Given this list of marker genes N4bp3, Alcam, Shank1, Marcks, Ptch1, Mmp3, Nos1, Abl1, Kcnip2, Grin2b, Rangap1, Grik1 (NCBI Gene Id 28183), Ica1, Plcb4, Mylk2, Mdga1, Mapk8ip3, Rph3a, Kcna2, Rgs10, Oprk1 (opioid receptor, kappa 1), Becn1, Gchfr, Slc4a8, Kif5a, Src, Sh3gl2, Dnajb1, Arhgap44 (NCBI Gene Id 216831), Slc1a1, Shisa8, Kcnb2, Cdk5r1, Ephb2, Rgs8, Zdhhc5, Cyp46a1, Osbp2, Shisa7 (shisa family member 7), Drd5, Syt11, Bdnf, Samd4, Htr5b, Hrh3, Kcne3, Prss12, Chrna5, Gabre, Rbm3, Anxa3, Arfgef2, Pabpc1, Dennd1a, Drp2, Rps6-ps4, Tenm2, Ntsr1, Scn8a, Acad9, Ago2, Mme, Itpr3, Gripap1, Kcnk2, Scgn, Calb2, Trpv1, Glra1, Itpr1, Sort1, Maob, Slc18a2, Slc12a5, Wfs1, Mink1, Strn4, Fxr1, Arhgap33, Aatk, Grik4, Dlgap2, Pi4k2a, Maf1, Homer1, Ncf1, Map1a, Lrfn3, Ift20, Robo1, Ppt1, Atp6ap2, Gnai2, Kif1c, Cyp19a1 (cytochrome P450, family 19, subfamily a, polypeptide 1), Kcnk9, Rack1, Septin4, Cd2ap, Cpeb3, Gria3, Srsf10, Mpdz, Penk, Cyp11b2, Rab17, Htr1b, Ppargc1a, Itpka (NCBI Gene Id 228550), Inpp5a, Pias3, Il6st (interleukin 6 signal transducer), C9orf72, Klhl20, Syn1, Grk4, Hspb1, Ucn, Kif21a, Ltbp1, Atp7a, Tanc2, Met (NCBI Gene Id 194383), Hnrnpu, Kif3b, Abr, Hip1r, Dlg3 (discs large MAGUK scaffold protein 3), Rab3ip, Als2, Npff, Hcn1, Zfp804a, Abi2, Hpca, Prex1, Tsc22d4, Ptpn6, Trim3, Adcy8, Fzd4, Slc32a1, Txnrd2, Chrm2, Fubp3, Gabra4, Ephb1, Cftr, Rps6, Ppfia2, Kpna1, Palmd (NCBI Gene Id 66688), Hspa8, Drd4, Cnnm4, Uhmk1, Apba3, Inpp5j (inositol polyphosphate 5-phosphatase J), Abl2, Shh, Hrh4, Gng3, Shisa6, Mtmr2, Kcnc4, Hsp90aa1, Hap1, Il1rapl1, Fzd3, Slc5a7, Itgb1, Lhfpl4, Gria2, Npcd, Glrb, Dab2ip, Slit2, Abi3bp, Rbm8a, Aplp2, Gnas, Strn3, Rufy3, Spg11, Rab8a, mt-Nd1, Syncrip, Atf4, Klhl17, Txn1, Fat3, Adcy9, Adcy4, Farp1, Dcx, Mt3, Zwint, Abhd12, Cabp1 (NCBI Gene Id 29867), Rpl28, Gopc, Homer3, Magi2, Ifngr1, Gabra5, Gnb3, Rin3, Cpe, Slitrk2 (SLIT and NTRK-like family, member 2), Mpp2, Chrna3, Vstm5, Dock10, Ppfia1, Mark1, Htr7, Sv2a, Cript, Thy1, Rtn4rl2, Brinp2, Brinp1, Ddn (NCBI Gene Id 328602), Slc9a6, Fyn, Syngap1, Reg1, Sez6, Chl1, Trappc4, Baiap2, Htr1d, Htr1a, Agap2, Bnip3, Tacr3, Actn1, Gata3un, Nlgn3, Ube2i, Ppp2r1a, Lrit3, Gphn, Epha3, Gpm6a (NCBI Gene Id 234267), Lgi1, Asic2, Wdr47, Pnmt (phenylethanolamine-N-methyltransferase), Ntf5, Kndc1, Lamp1 (NCBI Gene Id 234071), Cacng8, Cobl, Lama2, Ppp1cc, 4930544G11Rik (NCBI Gene Id 67653), Nf1, Gnb5, Ptprk, Epm2a, Grm3, Drd2, Numa1, Snx14, Pum2, Pcsk2, Pdyn, Whrn, Eif4b, Syndig1, Nectin1, Prr7, Tmem151a, Psen1, Gabarapl1, P2rx2, Slc38a2, Ppp1r2, Iqschfp, Nlgn4l, Nell2, Opa1, Trak2, Htr1f, Malat1, Pcsk5, Sri (sorcin), Ctnnb1, Fmr1, Cplx1, Ophn1, Elk1, Lzts1, Sgce, Hrh2, Eif4a3, Cnih3, Map6 (microtubule-associated protein 6), Plk3, Ncs1, Htr6, Htr2a, Nrdc, Prkcg, Adcy10, Kcnd2, Lrit1, Dhx36, Eif4a3l2, Cald1, Hdc, Ctnnd1, Cyfip1, Kcnh1, Ror2, Ngf, Tnk2, Elfn1, Cybb, Ppp3ca, Rab27a, Syap1, Mob4, Kcnj6, Rheb, Adora2a, Cx3cr1, Cacna1a, Lrrc7, Adora1 (NCBI Gene Id 98749), Zdhhc12, Ppp1ca, Sorbs2 (sorbin and SH3 domain containing 2), Calb1, Kcnip4, Ccr2, Hspa5, Rptor, Bace1, Oprm1, Cyba, Kcnn2, Apod, Syt7, Ykt6 (YKT6 v-SNARE homolog (S. cerevisiae)), Numb, Rasgrf1, Ccng1, Palm, Anxa5, Grm5, Sharpin, Atxn10, Cnn3, Cacna1d, Eif4a3l1, Adora3, Hcn4, Slc8a1, Tmem185a, Glra3, Ntsr2, Ngfr, Capn2, Igsf9, Clcn2, Fez1, Gipc1, Lynx1, Lrp2, Comt, Ilk, Mark3, Dpysl5, Grip2, Grid2, Dyrk1a, Dip2b, Ckap5, Amigo1, Skor1, Akap9, Gabra3, Brinp3, Ndfip1, Abhd17b, Shank2, Pdgfb, Adnp, Mast1, Gabra6, Prkar2b (NCBI Gene Id 19088), Slc8a3, Pick1, Abitram, Ift52, Fgf13, Grk3, Cacna1s, Git1, Arrb1, Srebf2, Sod1, Dlg1, Cfl1, Cryab, Hcfc1, C4a, Adcy2, Kcnq3, Mtor, Lrp8, Rap1gap, Abhd17a, Rtn1, Dagla, Flot2, Chrm1, Grik2, Bptf, Gabrb1, Rabgef1, Tiam1, Alox5, Rgs14, Bglap3, Dtnb, Cnga3, Zmynd8, Slc1a2, Sipa1l1, Trak1, Gria4, Kcnj14, P2rx4, Bcr, Necab2, Kif17, Casc3, P2rx6, Tmem108, Gnaz, Cdkl5, Jph4, Crtc1, Gabrg2, Kcnj4, Flna, Rgs7bp, Wls, Nsg1, Gsk3b (NCBI Gene Id 98033), Cdh9, Kirrel3, Grm6, Myo5a, Chrna4 (NCBI Gene Id 11438), Add1, Kcna4, Caprin1, Nptn (NCBI Gene Id 20320, neuroplastin), Rin1, Slc30a1, Septin14, Adam10, Pcsk1, Ada, Opn4, Kif1b, Cttn, Rgs11, Fxr2, Apbb1, Gper1, Unc80, Eef2k, Nsf, Zfp385a, Pclo, Grk2, Mcrs1, Kirrel1, Lsm1, Ctla2a, Epha10, Slc9a5, Reln, Dlg4, Cacna1c, Nfasc, Nlgn2, Dnm3, Aqp11, Slc1a4, Zfyve27, Mapt, Cacna1g, Strn, Elavl4, Ubxn1, Phaf1, Chrm3, Arrb2, Grid1, Pgr, Exoc4 (exocyst complex component 4), Rgs7, Rara, Crhbp, Gap43, Nefh, Chrm5, Adrb2, Grik3, Grm7, Gpr179, Gnao1, Gpr37, Cck, Rapgef4, Dpysl2, Slc4a10, Snap47, Dvl1, Prkca, Srcin1, Amfr, Cpeb4, Crcp, Capzb, Vmn2r1, Myl7, Map2k1, Clip2, Grm2, Grin1, Negr1, Ckb, Apba2, Dner, Cacna1b, Htr2b, Grm4, Arpc2, Drd1, Map2k4, Myh10, Mapk1, Mark2 (NCBI Gene Id 13728), Hrh1, Htr5a, Pcdh8, Trf, Arhgef2, Map1b, Atp2b2, Stx3, Dlgap4, Kif2a, Ccl2, Ccn3, Gnrh1, Gabrg3, Mlph, Nqo1 (NAD(P)H dehydrogenase, quinone 1), Syt4, Kcnk1, Atp1a3, Stx4a, Stau1, Dbn1, Espn, Nin, Dip2a, Sema4f, Omp, Hnrnpk, Epha4, Dcp1a, Glrx, Kcnip3, Azin2, Clstn3, C4b, Efnb2, Arf4, Homer2, Gng13, Glrx2, Max, Fas, Lrp1, Trp63, Snx1, Kcnip1, Lypd6, Ppp1r9a, Sema3a (sema domain, immunoglobulin domain (Ig), short basic domain, secreted, (semaphorin) 3A), Adgrb1, Tpgs1, Tmem222, Tubb3, Rhoa, Anks1b (ankyrin repeat and sterile alpha motif domain containing 1B), Ctnnd2, Map2, Gabbr1, Bglap, Slc17a8, Ephb3, Ptchd1, Ntf3, Elovl5, Kcnc2, Lzts3, Hcn3, Lrrc4, Crmp1, Ptk2b, Gabra2, Epha5, Kif1a (NCBI Gene Id 403189), Abi3, Rab5a, Pex5l, Ptprz1, Hnrnpr, Kcnj2, Rgs12, Lpar1, Septin11, Tpbg, Tmem266, Prnp, Ppp5c (protein phosphatase 5, catalytic subunit), Rps3, Grik5, Tmprss11c, Plec, Nsmf, Srgap2, Cpt1c, Epha8, Map1s, Gria1, Oprd1, Camk2a, Igsf9b, Dgki, Grm1, Itga8, Eif5a, Cpne6, Dbnl, Txn2, Gabrg1, Ptpn5, Zc3h14, Pnoc, Fus, Khsrp, Gigyf2, Ache, Rtn4r, Kifap3, Cnnm1, Bsn (bassoon), Synpo, Asap1, Rbm8a2, Kcnc1, Ncdn, Kcnab1 (potassium voltage-gated channel, shaker-related subfamily, beta member 1), Dtnbp1, Ppp1r9b (protein phosphatase 1, regulatory subunit 9B), Dbh, Cntnap4, Hnrnpab, Samd14, Nr3c1, Ar, Chrna7, Hcn2, Fcgr2b, Canx, Rac1, Th, Slc7a10, Psmc2, Atcay, Rplp0, Atxn1l, Lrrk2, Sfpq, Apc, Nectin3, Shisa9, Insr, Apoe, Lrp4, Ift57, Sumo1, Bmpr2, Bmpr1a, Plk2, Slc8a2, Igf2bp1, Crhr2, Ntrk1, Erbb4, Kcnd3, Plxdc1, Pak1, Pten, Pura, Bag2, Epha6, Rcvrn, Tnn, Trpc5, Nap1l4, Nlgn1, Mapk8ip1, Prkaa2, Ncoa2, Fscn1, Slc6a6, Taok2, Cib1, L1cam, Glrx5, Kcnb1, Tanc1, Cacna1h, Psd, Tsc2, Hdac6, Xrn1, Sorcs2, Myo5b, Tacr1, Atp1a2, Clstn1, Cd3e, Cntnap2, Gnaq, Grid2ip, Trim9, Ttll7, Kcnma1, Pdlim4, Ephb6, Kif21b, Chrm4, Ntrk2 (NCBI Gene Id 77471), Epha7, Brd1, Rit2, Bin1, Fzd5, Crhr1, Nrgn, Neurl1a, Ppp1r1b, Luzp1, Prrt2, Dlg2, Pde2a, P2ry1, Kcnj12, Ptk2, Clu, Ret, Asic1 (acid-sensing ion channel 1), Ybx1, Dmwd, Abhd17c, Grip1, Smo, Cdk5, Ngdn, Slc1a3, Arhgap32, Kcna1, Usp8, Glra4, Prkaa1, Myo1d, Ptpro, Gabra1, Pde4b, Arhgef15, Ank3, Lamp5, Sarm1, Akap5, Lmtk3, Apba1, Bcan, Arc, Dscam, Cdc42, Cacng3, Stat1, Dicer1, Cask (calcium/calmodulin dependent serine protein kinase), Kcnd1 (NCBI Gene Id 68749), Itsn1, Camk2b, Htr2c, Cadm1, Trpc2, Dlgap3 (NCBI Gene Id 277683), Begain, Cnr2, Atp2b1, Agtr1a, Inpp5f, Nsg2, Grin2a, Acvrl1, App (amyloid beta precursor protein), Avp, Gnb1, Kif3a, Clstn2, Glrx3, Cnih2, Camk2n1 (NCBI Gene Id 66259), Mapk8, Bmpr1b, Nr1d1, Ubxn2a, Abhd13, Kcnc3, Fbxo2, Trpm1, Gabrd, Bglap2, Hsp90ab1, Kif3c, Htt, Frmpd4, Enpp1, Shank3, Rogdi, Stau2, Ero1a, Htr4, Cplx2, Mark4, Mirc35hg, Psd2, Uri1, Cttnbp2, Trpm5, Kif5c, Unc5c, Klhl1, Map1lc3b, Magee1, P2rx3, Gabrb2, here is a description of the gene set: Mouse Gene Set: GOCC_DENDRITIC_TREE The entire complement of dendrites for a neuron, consisting of each primary dendrite and all its branches. studied in species Mus musculus